The following is a description of a gene set: species: Homo sapiens Any process that modulates the frequency, rate or extent of interleukin-4-mediated signaling pathway. Human Gene Set: GOBP_REGULATION_OF_INTERLEUKIN_4_MEDIATED_SIGNALING_PATHWAY, and this is the list of marker genes: PTPN2, CD300LF, PTPRC, PARP14, CD40